The following is a description of a gene set: species: Mus musculus Mouse Gene Set: GOBP_HEMATOPOIETIC_STEM_CELL_HOMEOSTASIS Any biological process involved in the maintenance of the steady-state number of hematopoietic stem cells within a population of cells., and this is the list of marker genes: P2ry14, Sox4, Smarca2, Foxa3, Adgrg1, Znhit1, Adar, Cadps2, Zfp251, Bmi1, Bap1, Ccn3, Gprasp2, Armcx1, Glis2, Crispld1, Myct1, Septin4, Arhgef5, Ubap2l, Ext1, Nle1, Tcirg1, Gata2, Fstl1, Fbxo21, Mtch2, Nbea, Stat4, Emcn, Tet2